Given this list of marker genes SMC1A, VPS11, RARS1, SCN1B, MCOLN1, PTPN23, PHGDH, GLB1, ACAN, RNH1, GABBR2, CDKL5 (NCBI Gene Id 6792), POLR2A, ACER3, ST3GAL5, MECP2, ZNHIT3, SATB1, NUP62, NTNG1, here is a description of the gene set: A cessation of the development of a child in the areas of motor skills, speech and language, cognitive skills, and social and/or emotional skills. studied in species Homo sapiens Developmental stagnation Human Gene Set: HP_DEVELOPMENTAL_STAGNATION